Given this list of marker genes Orai1, Fgl2, Ptpn1, Cxcl10, Tagap, Irf1, Gmppb (GDP-mannose pyrophosphorylase B), Fyn, Ddx60, Asb2, Gbp4, Slfn2, Pim1, Pfkp, Gadd45g, Nans, Psme2, Tarm1, H2-T23, Nlrc5 (NLR family, CARD domain containing 5), Ifi209, Themis2, Ccl17, Irgm2, Kmo, Pkib, Trim30d, Creld2, Snrpa, Socs3 (NCBI Gene Id 12702), Iigp1, Marchf5, Mob3c, Heatr1 (HEAT repeat containing 1), Ppp1r2, Prr5l, Eps8, Tap2, Kdr, Ccl2, Timm17a, Casp4, Gbp9, Cdkn1a (NCBI Gene Id 12575), Socs1 (NCBI Gene Id 12703), Bcl3, Prkx, Smarca5, Gbp3, Ifi47, Slc30a4, Stat1, Eif1a, Gpr35, Ccr5, Yrdc, Il3ra, Psmb9, Abcg1, Spint1, Lap3, Jak2, Gbp2, Snrpd1, Slamf8, Pnp, Batf, Ifi207 (NCBI Gene Id 98407), Serpina3f, Ly86, Srsf7, Cxcl9, Serpina3g, Trim30a, Sdc3, Gbp7, Ppa1, Sdhaf2, Tap1, Snx10, Gbp8, Acaa1a, Coro2a, Glrx, Tmem131, Scimp, Zyx, Igtp, Max, Bcl2a1b, Nampt, Samhd1, Slfn5, Oas1a, Dtx3l, Bex6, Ifi35 (interferon-induced protein 35), Irf5, Aida, Cd300lf, Tnfrsf1a, Pik3cd, Spi1, Oasl2, Tle3, Ms4a4c, Mndal, Pgs1, Bcl2a1d, Nop56, Cyth4, Arl8b (ADP-ribosylation factor-like 8B), Gbp5, Ifi204, Batf2, Eepd1, Cse1l, Stard3, Tmem106a, Irgm1, Ogfr, Gnl3, Olfm1, Parp9, Parp14, Cers6, Cox17, Psmb10, Cd40, Thoc6, here is a description of the gene set: from publication Cui A, Huang T, Li S, Ma A, Pérez JL, Sander C, Keskin DB, Wu CJ, Fraenkel E, Hacohen N (PMID 38057668) Cytokines mediate cell-cell communication in the immune system and represent important therapeutic targets. A myriad of studies have highlighted their central role in immune function, yet we lack a global view of the cellular responses of each immune cell type to each cytokine. To address this gap, the authors created the Immune Dictionary, a compendium of single-cell transcriptomic profiles of more than 17 immune cell types in response to each of 86 cytokines (>1,400 cytokine-cell type combinations) in mouse lymph nodes in vivo. A cytokine-centric view of the dictionary revealed that most cytokines induce highly cell-type-specific responses. For example, the inflammatory cytokine interleukin-1β induces distinct gene programmes in almost every cell type. A cell-type-centric view of the dictionary identified more than 66 cytokine-driven cellular polarization states across immune cell types, including previously uncharacterized states such as an interleukin-18-induced polyfunctional natural killer cell state. species: Mus musculus Mouse Gene Set: CUI_CDC2_IL12_RESPONSE_UP Genes positively differentially expressed in cell type: cDC2 (conventional dendritic cell type 2) upon treatment with cytokine: IL-12 in mouse lymph nodes in vivo.